The following is a description of a gene set: from publication Kyng KJ, May A, Stevnsner T, Becker KG, Kølvrå S, Bohr VA (PMID 15897889) Genes with GO annotation and down-regulated after DNA damage in cell lines from young donors. Human Gene Set: KYNG_DNA_DAMAGE_DN species: Homo sapiens The accumulation of DNA damage and mutations is considered a major cause of cancer and aging. While it is known that DNA damage can affect changes in gene expression, transcriptional regulation after DNA damage is poorly understood. We characterized the expression of genes in human primary fibroblasts after exposure to three different kinds of cellular stress that introduces DNA damage: 4-nitroquinoline-1-oxide (4NQO), gamma-irradiation, or UV-irradiation. Each type of stress elicited damage specific gene expression changes of up to 10-fold. A total of genes had similar changes in expression of 3-40-fold after all three kinds of stress. We examined transcription in cells from young and old individuals and from patients with Werner syndrome (WS), a segmental progeroid condition with a high incidence of cancer, and found various age-associated transcriptional changes depending upon the type of cellular stress. Compared to young individuals, both WS and old individuals had similarly aberrant transcriptional responses to gamma- and UV-irradiation, suggesting a role for Werner protein in stress-induced gene expression. Our results suggest that aberrant DNA damage-induced gene regulation may contribute to the aging process and the premature aging in WS., and this is the list of marker genes: MYD88, SLC31A2, GOLPH3, CAB39, SNX8, AGPAT1, MORF4L1, DNAJA1, CD53, PRELP, SAA1, PSG2, RHOBTB3, RBL1, RPL7A, RAP2A, TCF7L2, PDGFRL, VIM, DSCAM, SERPINB2, LCK, GBP1, CXCL2, TAF1C, CSDE1, COL3A1, NNMT, ATOX1, PCK2, CCNC, FBLN2 (NCBI Gene Id 2199), TXNRD2, APBA3, HEXB, TBCA, PTPN18, SGCB, GPD2, RAB11B, PPP1R14A, IL11RA, PRDX4, CCNH, TWF1, TPR, NMT1, ACE, MARK3, IFNGR2, SLC35B1, INPP1, TFPI2, IGFBP3, ENDOU, ITGB1, TLE1 (TLE family member 1, transcriptional corepressor), ARF1, CD36, HLA-DQA1, CSNK1A1, CDC25A, BEX3, SEMA7A, CEBPB, RAB7A, NRP2 (NCBI Gene Id 8828), COPS7A, ESD, GOLGA4, ALDH9A1, CYP51A1, RHOB, SEM1, ITGB8, NGF, SUOX, COPB2, RHOD (NCBI Gene Id 29984), MOK, CCNL2, IGF1, DAXX, IRF2, NET1, TGFB3, FGFR4, RAB6A, ARPC1B, MINK1, LOX, CALU, ACTN4, PBX1, ATRX, CRHBP, TIA1, PPA1, GYPB, PRKAB1, PSG1, KRT13, PRSS23, CTCF, ADAMTS1, IL10RB, MIR9-1HG, CRYAB (NCBI Gene Id 1410), PRKAB2, RABGGTB, MT1X, CNN1, BNIP3L, UGCG (NCBI Gene Id 7357), RIN2, CCNA2, PCNA, FMO4, PRKACA, NDRG1, GALNT2, ALDH3B2, IFNGR1, ANXA1, SERPINE2, TPM1, ANKRD11, ITGAL, CYCS, LCN2, HSD17B10, ST6GALNAC2, SSR3, RAB2A (NCBI Gene Id 5862), HGF, AKAP12, EIF3L, CSF2RB, BTG3, CDCA7, PTGER4, SEMA4D, MT1H, TNFRSF10B, FLOT1, CCN2, ITGB5, PPP2CA, SERPINB6, ID1, GLRX (glutaredoxin), LDHC, NDUFB6, CREBBP, CCND1, LSP1P4 (NCBI Gene Id 654342), EFNB1, CIR1, PDCD5, EGR1, SEMA3B, ATP5ME, SOD1, COG6, PAFAH1B3, TAF10, HSPB8, VDAC3, EIF4E, EPS8L1, PRKD2, LIMS1, GADD45A, TP53I11, POLR2F, FN1, CIB2, FGF2, AP3B2, CD69, OAZ1, PRMT1